The following is a description of a gene set: Mouse Gene Set: GOBP_CHITIN_METABOLIC_PROCESS The chemical reactions and pathways involving chitin, a linear polysaccharide consisting of beta-(1->4)-linked N-acetyl-D-glucosamine residues. species: Mus musculus, and this is the list of marker genes: Ctbs (chitobiase), Chi3l1, Chil3, Ovgp1, Chia1, Chit1, Chil5, Chil4, Chil6